Given this list of marker genes SLC20A2, here is a description of the gene set: part of: SLC transporter disorders Reactome Pathway: Defective SLC20A2 causes idiopathic basal ganglia calcification 1 (IBGC1) species: Homo sapiens The genes SLC20A1 and SLC20A2 encode for phosphate transporters 1 and 2 (PiT1 and PiT2 respectively). They both have a broad tissue distribution and may play a general housekeeping role in phosphate transport such as absorbing phosphate from interstitial fluid and in extracellular matrix and cartilage calcification as well as in vascular calcification. <br>They possess Na+-coupled phosphate (Pi) cotransporter function with a stoichiometry of 2:1 (Na+:Pi). Defects in SLC20A2 can cause idiopathic basal ganglia calcification 1 (IBGC1; MIM:213600), an autosomal dominant disorder characterised by vascular and pericapillary calcification by calcium phosphate in the basal ganglia and other brain regions. Affected individuals can either be asymptomatic or show a wide spectrum of neuropsychiatric symptoms including parkinsonism and dementia.